The following is a description of a gene set: species: Homo sapiens Genes predicted to be targets of miRBase v22 microRNA hsa-miR-934 in miRDB v6.0 with MirTarget v4 prediction scores > 80 (high confidence targets). Human Gene Set: MIR934 from publication Chen Y, Wang X (PMID 31504780), and this is the list of marker genes: FBXO22, PICALM, F11R, LRRN1, PYM1, SNX18, SLC35F2, PABIR3, FZD2, SPIN2B, STAR, PARVA, MRPL17, AHSA2P, ARL2BP, KMT2C, SFTPB, GNE, GLRA3 (glycine receptor alpha 3), MXI1, ZNF737, TFCP2L1, DENND10, MITD1, PAXBP1, ZNF655, MYPN, LMO4, HYAL4, ZDHHC11, HOXA4, KPNA1, BCCIP, SPIN1, C11orf87, ADNP, TFEC, GGNBP2, PDE6H, C1orf174, PDS5A, PDE11A, RBMS1, TCEAL7, UBE2E1, GPHN, PPEF2, LRRN3, C11orf58, SPIN2A, DCLK1, SLC16A1, SPCS3, DPY19L2, ESR1, DCLK2, BTN3A3, APOL4, SLA2, HOATZ, UFM1, SKP1, NOL3, OXR1, SLC35F1, PDC, ATP6V1C1, CYP1B1, SYNPO2, AGFG1, TRIM42 (NCBI Gene Id 287015), RBM19, CYTIP, EHD3 (NCBI Gene Id 30845), KANSL1, SLC39A10, AMELY, SLC2A4RG, LCMT2, GSR, RXFP1, MEFV